The following is a description of a gene set: Genes up-regulated in bone marrow-derived macrophages: untreated (0 min) versus IL10 and LPS (45 min). from publication El Kasmi KC, Holst J, Coffre M, Mielke L, de Pauw A, Lhocine N, Smith AM, Rutschman R, Kaushal D, Shen Y, Suda T, Donnelly RP, Myers MG Jr, Alexander W, Vignali DA, Watowich SS, Ernst M, Hilton DJ, Murray PJ (PMID 17114459) Human Gene Set: GSE5589_UNSTIM_VS_45MIN_LPS_AND_IL10_STIM_MACROPHAGE_UP species: Homo sapiens IL-10 or IL-6 stimulation of control 129xC57BL/6 murine bone marrow derived macrophages in the presence of LPS. We used microarrays to detail the global programme of gene expression changes in response to IL-6 or IL-10 stimulation in the presence of lipopolysaccharide. BMDMs were isolated from control, IL-6-/-, and IL-10-/- mice on a 129XBL/6 mixed background mice and differentiated in the presence of CSF-1 for 6-7 days. Cells were scraped and plated in 6 well plates at 2x10e6/well. Cells were washed with complete DMEM and rested for 1-2 hr before stimulation with combinations of IL-10 (10 ng/ml), IL-6 (2 ng/ml) or LPS (100 ng/ml) for 45 min or 180 mins. Complete biological replicates were performed., and this is the list of marker genes: MPG, HIGD1C (NCBI Gene Id 613227), OMA1, ISLR2, NOTCH1, CCNDBP1, TAP2, CFHR1, MPPE1, CTDSPL2, LDHB, PSMB9, ATP10D, ANTKMT, ATP23, MGAT4A, TRPS1, MEAK7, FCGR3A, TSPAN17, DNAJC4, TIMM21, CD274, DIPK2A, KLF3, MACROH2A1, CACNA1A, HLA-G, ILDR2, RBMS1, CSNK1D, ADGRE5, SDR42E1, CD74, B3GNT2, SOCS7, CA2, UBL3, PRPF4, NPPC (NCBI Gene Id 4880), ALG11, WDCP, IGSF8, SLC26A2, GPHN, ENG, NSRP1, SPATA1, EED, POC5, NIPSNAP1, LRRC41, INHBE, ZNF274, PEX6, TMEM50B, DOK1, LTO1 (ABCE maturation factor), DGUOK, HTRA2, TRMT2A, FAU, AP3B1, MSL1, PRMT9, UNC119, PIP4P1, RHEBL1, C8orf33 (NCBI Gene Id 65265), RNF41, PEF1, FAM222B, TOMM7, PISD, CRLF2, GNGT1, ZMYND12, MINDY1, ARHGAP1, ITGB1BP2, FAM117A, ARMC3, KIF3A, PPOX, CD47, DHDDS, SKI, VRK3, DECR2, GGA1, ATG13, PDE4A, RANBP9, TMEM177, GUK1, HES6, FHIP2A, COMT, PIK3R1, SPAG7, UGT2B4, VILL, GLCCI1, CWC22 (NCBI Gene Id 57703), GCFC2, RILP, PDZD8, SCYL1, TMBIM6, TLE6, SAMSN1, C3orf70, SAP30L, SENP2, DPF2, PDE7B, QTRT2, MAPK3, AHRR, TEX264, BRD4, PLA2G7, CD99, MAP2K2, EFHD2, TNFRSF19, TMEM192, ALAS1, UCK1, SLC9A4, PCGF2, B3GAT3, ARHGEF38, MAP1LC3B, CD300LD, VGLL4, TPRG1L, NDUFB7, NNT, CD27-AS1, LANCL1, PAPOLA, LPGAT1, CDS2, RABAC1, SLC25A11, SAYSD1, ING4, AATK, DNAJC10 (DnaJ heat shock protein family (Hsp40) member C10), WIPI2, RPS9, CHRDL2, IFT70B, AIFM2, MAPKAPK3, GRN, PQBP1, WBP11, EXOC6, SRPK2, DUSP2, NFKBIL1, WDR24, JADE2, RAB2B, ITM2C, IRF7, STAT6, PEX3, NGDN, DDHD1, CNOT8, PMS2, ZNF169, NR3C1, PDPK1, CTSD, EMB, TAPBPL, EHMT2, HLA-B, TNIP1, NIPAL4, ZMYND11, PLS1 (NCBI Gene Id 5357), ANGPT2, DNAJC13, SNRPB, SPATA16, NTF3, FEM1A, FANCM, CCSER2, SNX20, FLT3LG, ENDOD1, DHRS7 (dehydrogenase/reductase 7), LPIN2, ST3GAL4